Given this list of marker genes Ube2c, Mad2l1, Anapc10, Anapc7, Cdc23, Anapc2, Cdc26, Ube2e1, Anapc15, Ube2d1, Ube2s (NCBI Gene Id 77891), here is a description of the gene set: studied in species Mus musculus part of: Inhibition of the proteolytic activity of APC/C required for the onset of anaphase by mitotic spindle checkpoint components electronically inferred by orthology from the curated human pathway This event has been computationally inferred from an event that has been demonstrated in another species.<p>The inference is based on the homology mapping from PANTHER. Briefly, reactions for which all involved PhysicalEntities (in input, output and catalyst) have a mapped orthologue/paralogue (for complexes at least 75% of components must have a mapping) are inferred to the other species. Reactome Pathway: Inactivation of APC/C via direct inhibition of the APC/C complex